Given this list of marker genes MDM4, PTH1R (parathyroid hormone 1 receptor), APH1B, PTGDR, RAI1, ARL4C, SPARCL1, COL6A4P1, UPB1, MON1A, TNFRSF25, SPON1, STX2, UNC13B, IFT172, EFCAB8, CD300E, AKAP8, ADCY6, TRPV5, TCF7, RALGPS2, PANK4, MFAP2, ESAM, PTPN14 (protein tyrosine phosphatase non-receptor type 14), PFKFB2, FOXP1, SDK2, PRG3, SMIM31, SKIC2, BPTF, H6PD, BBOX1, GRAMD1C, CDH6, NMUR1, ZDHHC22, CNGB1, KCNJ1, ACIN1, NEURL4, NOTCH3, CD163L1, IGF1R, FAN1, TRIM3, FERMT1, ATXN7L2 (ataxin 7 like 2), SLC27A5, GRAMD4, DZIP1, ZCCHC13, PIGP, MBP, NLGN3, LYNX1, SPATS1, HOXB9, ARSJ (NCBI Gene Id 79642), TRUB1, DDX51, APEX2, LUC7L, TMC4, BRF1, NXPH4, PABPC4, SLC16A8, ZFP64, PRDM8, CC2D1A, MN1, DENND5B, DDX4, CACNB2, RAB33A, CHD6, FLRT1, ZSCAN10, FHIP2B, MIR23B, PEAR1, LYSMD1, SATB1, SPO11, CUL9, KRT78, SHISA4 (NCBI Gene Id 149345), SIPA1L2, PINK1, SPG11, TASP1, BACE1, USP3, DRC3, KRT86, GLT8D1, ACP5, FBXO24, CCDC78, GIGYF1, PRM3, RXRB, ARHGAP15 (NCBI Gene Id 55843), BAHD1, SLFNL1, ZSWIM4, IPO4, TNFRSF12A, DCHS1, MAOA, ZWINT, ESRP2, OTOP1, BSX, C1QTNF3, PCYT2, C4BPA, SHE (NCBI Gene Id 126669), ADAMTSL2, STON2, COLGALT2, GPR180, ABHD11 (abhydrolase domain containing 11), EGF, TTC32, NCKAP5L, CMAHP, KLHDC7B (NCBI Gene Id 113730), IVD, NETO2, KYAT1, DNALI1, CDH10, GOLM2, HSDL1, IGSF21, CIDEB, CLCF1, CDHR4, ANKRD13D, PLA2G6, here is a description of the gene set: from publication Cipolletta D, Feuerer M, Li A, Kamei N, Lee J, Shoelson SE, Benoist C, Mathis D (PMID 22722857) Genes up-regulated in CD4 T cells over-expressing FOXP3 and Pparg2 isoform of PPARG: untreated versus pioglitazone. Human Gene Set: GSE37533_UNTREATED_VS_PIOGLIZATONE_TREATED_CD4_TCELL_PPARG2_AND_FOXP3_TRASDUCED_UP studied in species Homo sapiens We identified Pparg as a major orchestrator of the phenotype of adipose-tissue resident regulatory T cells (VAT Tregs). To explore the contribution of Pparg1 and 2 in the generation of the VAT Tregs-specific gene signatures, CD4+FoxP3- T cells were transduced with Foxp3+/- Pparg1 (or Pparg2), treated with Pioglitazone or vehicle, and double sorted for microarray analysis.